Given this list of marker genes CTNS, GSTT1, GGT2P, GGTLC1, IDH1, GSTZ1, GSTM5, GLRX2, CHAC2, GGT5, SOD2, MGST2 (microsomal glutathione S-transferase 2), GPX1, GGT1, DPEP1, GSR, NFE2L2, GSTP1, HPGDS, GGTLC2, SLC1A1, GSTK1, GSTA3, GSTA1, GSTT2B, GSTA5, ETHE1, GGTLC3, GSTM4, GGT3P, CHAC1, GSTM3, GGT6, SLC1A2, NFE2L1, G6PD, GSTO2, SLC7A11, AAAS, NAT8, GSS, MMACHC, GSTO1, ARL6IP5, GLO1, GSTA4, GSTM1, GCLM, GSTT4, GSTA2, HAGH, GGT7 (gamma-glutamyltransferase 7), GSTM2, NDP, GCLC, SOD1 (NCBI Gene Id 6647), OPLAH, GSTT2, here is a description of the gene set: Human Gene Set: GOBP_GLUTATHIONE_METABOLIC_PROCESS species: Homo sapiens The chemical reactions and pathways involving glutathione, the tripeptide glutamylcysteinylglycine, which acts as a coenzyme for some enzymes and as an antioxidant in the protection of sulfhydryl groups in enzymes and other proteins; it has a specific role in the reduction of hydrogen peroxide (H2O2) and oxidized ascorbate, and it participates in the gamma-glutamyl cycle.